The following is a description of a gene set: Human Gene Set: HP_INCREASED_ADIPOSE_TISSUE Increased adipose tissue An increase in adipose tissue mass by hyperplastic growth (increase in the number of adipocytes) or by hypertrophic growth (increase in the size of adipocytes occurring primarily by lipid accumulation within the cell). species: Homo sapiens, and this is the list of marker genes: POLR3A, PIK3CA, INPP5K, MC4R, AKT2, MT-TK, LMNA, PCSK1, POMC, CHCHD10, LIPE